Given this list of marker genes ANOS1, ADGRV1, IQSEC1, CCNI, EPPIN, MKKS, CDH8, NPAS1, PLA2R1, EFCAB14 (NCBI Gene Id 9813), FARP2, ABCC3, SLC28A2, TENT5A, GSE1, PRR5L, TAS2R14, LTBP2, IL5RA, ZFYVE9, ZNF185, FBXO40, LRRC37BP1, SNCAIP, CAT, GNRHR, CAND2, RSAD1, PILRA, GPR25, RTN1, FLRT1, UBAP1, APOB, G6PC2, VPS51, DPP6, TP53I11, EXOC7, PSD, MMP20, NCAM1, TP53TG1, CDSN (NCBI Gene Id 56798), DAZAP2, KIF5A, AKR1C1, MUTYH, TRIM44, CYP3A5, SIGIRR (NCBI Gene Id 59307), BPNT1, CDC14A, FRMPD1, PDZD2, SCRG1, URGCP, HEXA-AS1, TPD52L1, FGF7, BNC2, SCAF4, NCOA1, ELF4, GAD2 (glutamate decarboxylase 2), HPS1, STS, CATSPERB, UPK3A, BOLA1, SPI1, RAB7A, SLC17A1, SAP30L-AS1, ADA2, IGHA1, MAPK1, CELA2A, PLXNC1, S100A7, XKR8, POMGNT1, SLC10A3, ZCCHC4, HECW1, LILRA3, NPR3, UBE2D4, GABRR1, DEFA6, PIGT, MYO16, LINC00667, MVB12B, CUBN, SPTLC3, GPR39 (NCBI Gene Id 2863), PEX7, PRKAR2A, SFN, DNAH2, ZNF484, ANXA1, ADARB1, SLC25A22, KLHDC8A, FAM186A, RHOBTB3, PKNOX2, GABBR1 (NCBI Gene Id 2550), TTC19, TP63, NXF2, VCL, ADGRE5, CELSR2, RNF139, PIK3IP1 (NCBI Gene Id 113791), CYP2C19, WNT11, PREX2, RNF4, IFNAR2, H3C6, TUBA4B, ASAH1, SIN3B, AR, MAP2K6, MYCL, C11orf71, DOLPP1, OR2B6, GCNT4 (glucosaminyl (N-acetyl) transferase 4), ZNF34, ARRB1, OR1F2P, DAB2, BIN2, B3GALT5, HNRNPA1, ABCD4, TDRKH, LIPG, AP3S1, RLN1, KLF4, THRB, LPP, GPRC5A, BBS1, OGFRL1, EXPH5, EP400, SIPA1L3, IL25, AQP1, EPHB1, ARAP1, NHLH2, ACVR2A (activin A receptor type 2A), LIFR, PKD1L1-AS1 (PKD1L1 antisense RNA 1), ACSS3 (NCBI Gene Id 79611, acyl-CoA synthetase short chain family member 3), ITGA10, GABRD, CHST15, HCG4B (HLA complex group 4B), PCSK7, NXF1, HNMT (NCBI Gene Id 3176), HLA-C, PPP2R3A, OR10H2 (olfactory receptor family 10 subfamily H member 2), YIPF1, FPR2, P3H4, ZNF506, PTPN12, PI15, EFNA5 (ephrin A5), ZNF629, SRPK2, CACNA1A, TOM1L2, RNF220, CD44, MAML3, CFD, SLC22A18AS, KCTD14, FGF22, GRIK3, CCDC40, RNASE3 (ribonuclease A family member 3), here is a description of the gene set: In the present study we used Affymetrix oligonucleotide microarrays to produce gene transcription profiles for the major leukocyte types in humans. This comprehensive dataset enabled us to not only establish which genes were expressed in each leukocyte type, but also which genes were expressed in each subset after activation. The used of a comprehensive dataset of gene profiles from all the major human leukocyte subsets enabled a novel and powerful means for identification of genes associated with single leukocyte subsets, or different immune paradigms. species: Homo sapiens Genes up-regulated in comparison of NK cells versus Th1 cells. Human Gene Set: GSE3982_NKCELL_VS_TH1_UP from publication Jeffrey KL, Brummer T, Rolph MS, Liu SM, Callejas NA, Grumont RJ, Gillieron C, Mackay F, Grey S, Camps M, Rommel C, Gerondakis SD, Mackay CR (PMID 16474395)